Given this list of marker genes Uba52, Rps27a, Ubb, Uba52rt, Smad7, Tgfbr2, Ubc (ubiquitin C), Tgfbr1, Bambi, Pmepa1, Stub1, Strap, Smad2, Smurf2, Smad3, Tgfb1, Mtmr4, here is a description of the gene set: studied in species Mus musculus Downregulation of TGF-beta receptor signaling Mouse Gene Set: REACTOME_DOWNREGULATION_OF_TGF_BETA_RECEPTOR_SIGNALING